The following is a description of a gene set: Human Gene Set: REACTOME_BETA_OXIDATION_OF_VERY_LONG_CHAIN_FATTY_ACIDS studied in species Homo sapiens Beta-oxidation of very long chain fatty acids, and this is the list of marker genes: MLYCD, ECI2, ABCD1, ACOX1, HSD17B4, ACOT8, SLC27A2, EHHADH, ACOT4, ACAA1, DECR2